The following is a description of a gene set: studied in species Homo sapiens Genes up-regulated in mature plasma cells compared with plasmablastic B lymphocytes. Plasma cells (PCs), the end point of B-cell differentiation, are a heterogeneous cell compartment comprising several cell subsets from short-lived highly proliferative plasmablasts to long-lived nondividing fully mature PCs. Whereas the major transcription factors driving the differentiation of B cells to PCs were recently identified, the subtle genetic changes that underlie the transition from plasmablasts to mature PCs are poorly understood. We recently described an in vitro model making it possible to obtain a large number of cells with the morphologic, phenotypic, and functional characteristics of normal polyclonal plasmablastic cells (PPCs). Using Affymetrix microarrays we compared the gene expression profiles of these PPCs with those of mature PCs isolated from tonsils (TPCs) and bone marrow (BMPCs), and with those of B cells purified from peripheral blood (PBB cells) and tonsils (TBCs). Unsupervised principal component analysis clearly distinguished the 5 cell populations on the basis of their differentiation and proliferation status. Detailed statistical analysis allowed the identification of 85 PC genes and 40 B-cell genes, overexpressed, respectively, in the 3 PC subsets or in the 2 B-cell subsets. In addition, several signaling molecules and antiapoptotic proteins were found to be induced in BMPCs compared with PPCs and could be involved in the accumulation and prolonged survival of BMPCs in close contact with specialized stromal microenvironment. These data should help to better understand the molecular events that regulate commitment to a PC fate, mediate PC maintenance in survival niches, and could facilitate PC immortalization in plasma cell dyscrasias. from publication Tarte K, Zhan F, De Vos J, Klein B, Shaughnessy J Jr (PMID 12663452) Human Gene Set: TARTE_PLASMA_CELL_VS_PLASMABLAST_UP, and this is the list of marker genes: IGLC1, PSG7, SKAP1, CD3E, TIMP3, FLNB, FCN1, ITGA3, ACTB, HTR2C, APOE, GNG4, SIRPA, ADRB3, TGFB3, GABRA1, IGHD, CFTR, IFNA21, MX1, CUL7, ENO2, CD8B, PCDH1, NFKBIA, ALDH7A1, TJP1, MCAM, NELL2, H2BC15, RPS15, CELA3A, RAPGEF5, GRN, HLA-DQA1, RPL28, CFB, CTLA4, CHN1, KRT83, TRIM22, HOXD10, SDC1, PIK3R2, PLCB2, LGALS9, CXCL12, HTR1E, HHEX, PTPRN, BMP4, GPX3, HLA-DOB, SLC18A1, IGLC7 (immunoglobulin lambda constant 7), MPO, APOC1, MAG, RAB13, EGR1, CES1, HSF4, SPIB, TACR3, VCAM1, TPT1 (tumor protein, translationally-controlled 1), AVPR1B, IGFBP4, FUCA1, MYBPC2, ITPKB, OAZ1, HSPA1B, RPL24, AQP2, TCEAL1 (NCBI Gene Id 96422), ALOX5AP, IFITM3, CRIPTO3 (cripto, EGF-CFC family member 3), CTSL (NCBI Gene Id 1514), SLC5A5, NBL1, CD3D, FCER1G, SERPING1, TRBV9, TCL1A, MME, MLN, TBC1D5, ITGAD, KRT6C, CACNA1B (NCBI Gene Id 774), COL1A1, REG1A, KCNQ1, S100A9, HBD, LGMN, MMP9, HLA-DQB2, ITGAX, STXBP1, GPC1, CDH15, RPS15A, FCGR3B, TNP1, RBPMS, CR1, PCDHGC3 (protocadherin gamma subfamily C, 3), LRRC23, RPS11, IFI44L, MTCYBP5, SPRR2A, KRT33B, ENOX2, PTPRK, PBX2, MERTK, CBLB, WWOX, MPP3, CSF1 (NCBI Gene Id 1435), BTG2, HERPUD1, AK1, KANK1, CSN3, SERPINA3, LTBP2, CXADR, LRP1, KRT1, GPR18, PSAP, TNXB, MDK, ZNF787, CD22, LYZ, IFIT5, PHB2, DLG4, ITGA2B, TCN2, SPRR1A, HTR1B, BIRC3, NHLH1, RPS2, ACTC1, CST3, LTC4S, ADM, ZNF141, ACRV1, PDE4A, GPNMB, PHOX2B, CYBA, CCR7, CRYAB, FTL, MAPKAPK2 (MAPK activated protein kinase 2), PFKFB3-AS1, SSR4, HBA1, TBXA2R, CIRBP, SORL1, IFITM1, S100A8, SERPINB4, DMD (NCBI Gene Id 548327), EOLA1-DT, AGER, IL7R, IGLJ1, CD9 (NCBI Gene Id 928), MPZ, AQP5, PFN2, MITF, DEFA5, TNFAIP2, SATB1, YES1, TNFAIP3 (NCBI Gene Id 7128), SLC15A2, JUP, PCOLCE, PAX6, TNC (tenascin C), CNTNAP1, ZNF117 (zinc finger protein 117), C4BPA, RPS14, KRT6A, FGR, HEXA, RUNX1, CCR9, CPA3, HRH1, SLC14A2 (NCBI Gene Id 8170), PRKACG, FEV (NCBI Gene Id 54738), SPTB, H4C9, RPS18, CDR2L, CYFIP1, RNASE1, SLC30A3, TRAF1, CYP2C9, HOXB13, ENSG00000310059, KRT32, CLU, ARHGEF16, SYPL1, CRABP2, GAA, SPRR2C, SMPD1, RPS21, IFI44, HSPB1, TSC22D3, IKBKE, BRD3, GNB3, CD24, RGS2, BTN2A2, APOC2, GNA11, DDR2, ZNF157, IGLV4-3, DAB2, JADE2, RAB32, EFNB1, NFIC, STX1A, MT1B, RPL39, CCSER2, PPM1F, HOXB2, SERPINB6 (NCBI Gene Id 5269), NOP14-AS1, GPLD1, CALB2, ANKRD46, NREP, ADH4, MYL2, MC4R, MGST2, BCR, DDR1, CHRM4, P2RX1, IDUA, CDSN, C1S, CCL22, FSTL1, COL11A1, KCNMA1, TPM1, ZNF132, ADCYAP1, CBS, DOCK1, CDKL5, VPREB1, NFKB2, ITIH4, NCAM1, GYPB, RPSA, TGIF1, GPER1 (NCBI Gene Id 2852), KISS1, SNCA, ADORA3, B2M, CHERP, PALM, LST1, TIAM1, GMPR, SPINT2, FOSB, RBMS2, PCK1, FABP3, LCN2, MYL5, SMPDL3B (sphingomyelin phosphodiesterase acid like 3B), MYO1C, IL4R, RPL18A, NR4A1, FBP1, ATF6B, RNASE3, PCSK6, APOC3 (NCBI Gene Id 440838), ADAM8, CXCL8, CXCR2, ELAVL3, ZNF32, RPLP1, DPP6, RBP3, DAPK1, HLA-F, FBN1, RPL7A (ribosomal protein L7a), COL14A1, CSN2, JUND, ELANE, ERCC4, MX2, MIA3, RELB, MMP16, MYL11, ALDH1A1, WNT10B, FEZ1, PLPP3, SMAD1 (SMAD family member 1), NOTCH4, CD34, SGSH, COL4A1, S100P, HES1, GCM1, KRTAP1-1, LINC01587, AMPD1, SERPINA1, CPB1, TLR1, IGKC, KLK3, HLA-B, HP, RUNX1T1, RPL34, FSCN1 (fascin actin-bundling protein 1), LRRC14, HPN, PTGDS, AEBP1, DUSP1, ITGA8, GZMA, RPLP0, CD40, MYCL, C4A, NOS2 (NCBI Gene Id 4843), LINC02967, FOLR1, RPL37A, ASMT, FCGRT, RPS16, FOS, ALDH2, FRZB, OPRM1, PAM, ZNF142, MSX1 (NCBI Gene Id 4487), QPCT, FLT4, FMOD (fibromodulin), ZFHX3 (zinc finger homeobox 3), PRKAR2B, CEACAM4, CYP1A2, CHIC1, CD72, SLC10A2, CYP2A6